The following is a description of a gene set: The series of events involved in the perception of smell in which an olfactory chemical stimulus is received and converted into a molecular signal. Mouse Gene Set: GOBP_DETECTION_OF_CHEMICAL_STIMULUS_INVOLVED_IN_SENSORY_PERCEPTION_OF_SMELL studied in species Mus musculus, and this is the list of marker genes: Or2t35, Or10a3n, Or10ag57, Or2y16, Or12j3 (NCBI Gene Id 258512), Or2f2, Or2d2b, Or10al6, Or10g7, Or6b13, Or12d15, Or10d1b, Or2z9, Or2ag19, Or10a48, Or5p52, Or13d1, Or10am5, Or2h2c, Or2ah1, Or2ak4, Or13g1, Or2h1b, Or13p4, Gm7582, Or12k5, Or1j1, Or2ak7, Or2y8, Or2a51, Or2w6, Or10ab4, Or10u4, Or2c1, Or13p5, Or2g25, Or10d4b, Or2d3b, Or2y17, Or5m5, Or2ag2b, Or12d13, Or10al3, Or10j2, Or10h1b, Or5d20-ps1, Or10a49, Or2g1, Or2a56, Or3a10, Or2a20, Or13ae2 (olfactory receptor family 13 subfamily AE member 2), Or5g9, Or7a42, Or2ag1b, Or7d11, Or5p67, Or2a25, Or12j5, Or10ag2, Or6b1, Or2w2, Or1j21 (NCBI Gene Id 258948), Or8u3-ps, Or10k2, Or6k6, Or10ak12, Or2aa1, Or6y1, Or10a3m, Or10d1c, Or2q1, Or11i1, Or2m13, Or2v1, Or7e178, Or2n1d, Or2t49, Or13c7b, Or13c7c, Or2ag16, Or10j7, Or2i1, Or10p22, Or10ag56, Or2ad1, Or13p8, Gm7609, Or10aa3, Or4e2, Or10j3, Or5p76, Or9g19, Or6e1, Or2f1, Or10a4, Or10al2, Or2t48, Or6n1, Or5p81, Or5b21, Or13c25, Or2t45, Or2y11, Or10s1, Or2y1, Or5p80, Or2t1, Or4c3d, Or2j3, Or2ak5, Or8g17, Or6k2, Or10u3, Or10ah1-ps1, Or10ak13, Or6ae1, Or5p57, Or12j4, Or10c1, Or2b2, Or12e10, Or5v1, Or10ab5, Or5p72, Or5p6, Or2t46, Or2b7, Or2y13, Or6b9, Or10ak8, Or2y1g, Or8a1, Or10ak9, Or10g1b, Or2l13b, Or10a3b, Or6n2, Or2ag1, Or2a14, Or2y1b, Or2r2, Or10d4, Or12d12, Or10ag54, Or10d5j, Or5g25, Or10ak16, Or2k2, Or2v2, Or6aa1, Or2d3, Or2m12, Or5t9, Or10ag58, Or5p53 (NCBI Gene Id 258771), Or12d17, Or2a7, Or12k8, Or2ag15, Or6p1, Or2y12, Slc24a4, Or11m3, Or12e13, Or1r1, Or12d2, Or10ak11, Or10al5, Or10a5, Or10a3 (olfactory receptor family 10 subfamily A member 3), Or10d5, Or12j2, Or12e1 (NCBI Gene Id 258655), Or5p55, Vmn2r1, Or2t47, Or10g3b, Or2n1e, Or10a2, Or5g29, Or2aj6, Or2t43, Or13j1, Or2ag20, Or5h17, Or2a52, Or2y1e, Or10z1 (NCBI Gene Id 258710), Or2w1, Or2b28, Or2y15, Or5p70, Or2y1c, Or10ak14, Or2ag18, Or2w3, Or9s13, Or2f1b, Or5p62, Or5p4 (olfactory receptor family 5 subfamily P member 4), Or2o1, Or2a57, Or2ag17, Or5p51, Or2y6, Or8b3, Or2j6, Or4m1, Or2t6, Or2a5, Or2p2, Or5g26, Or13c7d, Or10al4, Or13n4, Or2y3, Or13c3, Or8c8 (NCBI Gene Id 258802), Or2av9, Gm15433, Or2aj5, Or51e2, Or5p56, Or13c7 (NCBI Gene Id 29845), Or6k14, Or12d16-ps1, Or8g50, Or10j5, Or5ap2, Or2d2, Or2g7, Or5an6, Or10g3, Or13p3, Or2t26, Or2d4, Or2n1b, Or4e1, Or10j3b, Or2w3b, Or5p68, Or5p50, Or10h5, Or2y1f, Or5v1b, Or7a40, Or6k4, Or2a12, Or2h2, Or7r1, Or5p64, Or10j27, Or2n1c, Or2r11, Or10g1, Or8b8, Or2b4, Or10ag60, Or4b13, Or2y14, Or2w25, Or12e8, Or5p58, Or13f5, Or2z2 (NCBI Gene Id 258878), Or12d14-ps1 (NCBI Gene Id 257948), Or10h1, Or2ag13, Or5h19, Or10aa1, Or13e8, Or10ak7, Gucy2d, Or2ag2, Or10ag53, Or5t18, Or2b11, Or2d3c, Or10ag52, Or5ar1, Or12e9, Or2w4, Or8g18, Or2t44, Or12e14, Or2h15 (NCBI Gene Id 435547), Or5t7, Or2b6, Or10n1, Or10g9b (olfactory receptor family 10 subfamily G member 9B), Or6z7 (NCBI Gene Id 258916), Or12e7, Or2l13, Or10al7, Or5k17, Or10d1, Vmn2r26, Or8u9, Or2d36, Or10p1, Or2ak6, Or2y1d, Or4e5, Or10ac1, Or2aj4, Or2t29, Or13p10, Or1m1 (olfactory receptor family 1 subfamily M member 1), Or5k16, Or5h18, Or2b2b, Or2h1, Or1e16, Or5p59, Or10ad1, Or10g9, Or2l5, Or10g6, Or5j3, Or56b34, Or10ag59, Or10w1, Or10d4c, Or5p69, Or2y10, Or5p54, Or5p66, Or5t17, Or2r3 (olfactory receptor family 2 subfamily R member 3), Or2bd2, Or2z8, Or10ad1b (olfactory receptor family 10 subfamily AD member 1B), Or5p60 (NCBI Gene Id 258492), Or2ag12, Or10d3, Or2a54, Or2n1, Or5p73, Or13a1, Or2ab1 (NCBI Gene Id 257892), Or10h28, Or5p79, Or2w1b, Or6a2, Or5p1